Given this list of marker genes LCAT, GCKR, ATP5F1D, PPP1R1A, SC5D, H1-6, CUX2, NAP1L3, ART1, CHRNA5, LHCGR, PMP2, FDX1, ENPP1, CDA, ST3GAL6, ZBTB5, CTNND1, THRB, COBLL1, HSPBP1, PMM1, PRKAR1B, GCHFR, SLC35D1, U2AF2, SULT1A1, GAB1, PKIA, POU3F2, PSMB3, MME, PITX1 (NCBI Gene Id 5307), PCYT2, SMCP, PEMT, SMAD1, TEK, GHRHR, ACP2, DACH1, URB2, USP14, APBA1, ADRA2B, SPINK5, PHGDH, CDH17, DHRS2, MAOA, BPI, HAAO, TESK1, GARNL3, INSM1, GLRA2, PIR, PPOX (NCBI Gene Id 7440), TJP2, USF2, GADD45G, TMEM11, PRL, CASP6, RHAG, ALAD, ADRA1A, ZER1, MOBP, ITPRID2 (NCBI Gene Id 6744), here is a description of the gene set: from publication Hoshida Y, Villanueva A, Kobayashi M, Peix J, Chiang DY, Camargo A, Gupta S, Moore J, Wrobel MJ, Lerner J, Reich M, Chan JA, Glickman JN, Ikeda K, Hashimoto M, Watanabe G, Daidone MG, Roayaie S, Schwartz M, Thung S, Salvesen HB, Gabriel S, Mazzaferro V, Bruix J, Friedman SL, Kumada H, Llovet JM, Golub TR (PMID 18923165) Human Gene Set: HOSHIDA_LIVER_CANCER_LATE_RECURRENCE_DN BACKGROUND: It is a challenge to identify patients who, after undergoing potentially curative treatment for hepatocellular carcinoma, are at greatest risk for recurrence. Such high-risk patients could receive novel interventional measures. An obstacle to the development of genome-based predictors of outcome in patients with hepatocellular carcinoma has been the lack of a means to carry out genomewide expression profiling of fixed, as opposed to frozen, tissue. METHODS: We aimed to demonstrate the feasibility of gene-expression profiling of more than 6000 human genes in formalin-fixed, paraffin-embedded tissues. We applied the method to tissues from 307 patients with hepatocellular carcinoma, from four series of patients, to discover and validate a gene-expression signature associated with survival. RESULTS: The expression-profiling method for formalin-fixed, paraffin-embedded tissue was highly effective: samples from 90% of the patients yielded data of high quality, including samples that had been archived for more than 24 years. Gene-expression profiles of tumor tissue failed to yield a significant association with survival. In contrast, profiles of the surrounding nontumoral liver tissue were highly correlated with survival in a training set of tissue samples from 82 Japanese patients, and the signature was validated in tissues from an independent group of 225 patients from the United States and Europe (P=0.04). CONCLUSIONS: We have demonstrated the feasibility of genomewide expression profiling of formalin-fixed, paraffin-embedded tissues and have shown that a reproducible gene-expression signature correlated with survival is present in liver tissue adjacent to the tumor in patients with hepatocellular carcinoma. species: Homo sapiens Genes whose expression correlated with lower risk of late recurrence of hepatocellular carcinoma (HCC).